The following is a description of a gene set: studied in species Homo sapiens Human Gene Set: GOBP_CONNECTIVE_TISSUE_DEVELOPMENT The progression of a connective tissue over time, from its formation to the mature structure., and this is the list of marker genes: UMODL1, SNX19, PRRX1, BBS1 (Bardet-Biedl syndrome 1), BBS2, HES5, ACAT1, RARB, MEX3C, BMP10, ZMPSTE24, SORL1, MIR125A, MMP13, SH3PXD2B, SMAD7, ID2, THRA, FKRP, MATN3, TGFB2, PTH1R, IL17F, PPARD, GPR82, FGF2, GREM1, BMP5, HAND1, PDGFA, PUM2, TRPM4, ECM1, MKKS, MYCN, TRPV4, LEP, CFLAR, ERRFI1, SCIN (scinderin), OSR2, RFLNA, PDGFB, LTBP3 (NCBI Gene Id 4054), NAMPT, TIMP1, MATN1, EGR1, ACTA2, PBXIP1, TBL1XR1, PARP1, CASR, FGFR3, ZBTB16, FOXC2, WNT2B, HYAL3, HSD17B1, PPARGC1A, GDF2, CER1, MGP, RARG, FGF4, COL3A1, SMAD5, PLAAT3, GLI3, PTHLH, RASAL2, BMPR2, AMELX, ZNF516, LUM (NCBI Gene Id 4060), DGAT2, EIF2AK3, NKX3-2, SPTLC2, NFIA, RUNX3, EPYC, TGFBR2, PKD1, ARRDC3, ARID5B, WNT5A, PAXIP1, SNAI1, GHRL, SLC39A13, ZNF219, IGF1, SLC39A14, AMER1, ADAMTS7, SMPD3 (NCBI Gene Id 79756), FOXA1, TRPS1, MAF, BMP7, TGFBI, PPARG, GDF5, ITGB3, ADAMTS12 (NCBI Gene Id 81792), MAPK3, CTNNB1, GUCA2B, COL6A1, CNMD, MIR21, LNPK, OSR1, KLF7, FGF6, TSKU, CSGALNACT1, PTH, SLC26A2, SATB2, PDGFRB, NCOA1, PDGFD, OTOR, SLC25A25, LIPA, MBOAT2, GHR, NOTCH1, CHI3L1, PGRMC2, WNT10B, OXCT1, RUNX1, CD44, EFEMP1, PIK3CA, BMP8B, EDN1, SMAD3, XBP1, CREB3L2, NPR2, BMP6, FRZB, VPS13B, WNT11, HYAL1, SPI1 (NCBI Gene Id 6688), HAND2, HYAL2, ADGRG6, NR5A2 (NCBI Gene Id 8768), CCN3, SELENOM, SCX, DYRK1B (dual specificity tyrosine phosphorylation regulated kinase 1B), GLG1, CD34, SERPINH1, SOX5, CD2AP, MSX2, BMPR1B, FGF9, EXT2, BMP4, BMP2, ASNSD1, IFT80, COL5A1, HOXA5, FGF18 (NCBI Gene Id 8817), HMGCS2, HOXB3, TGFB1, BBS4, EVC, CHSY1, TAPT1, COL1A1, THBS3, CCN4, PKDCC, WNT7B, CSF1, ENSG00000274276, FTO, GDF7, MSX1, AXIN2, SHOX2, GDF6, HOXA11, GPR4, SMAD1, FAM83A, WNT9A, COL27A1, MEF2C, ARID5A, HMGA2, HOXD3, BMP3, NFIB, OGN, PAX7, COMP, SIRT1, SOX8, MAPK14, SNAI2, TGFBR1 (transforming growth factor beta receptor 1), NFATC2, SERPINB7, NOG, WT1, BARX2, PRKG2, SOX6, GPLD1, POU4F2, CYTL1, IL6R, CHADL, RORC, TWSG1 (twisted gastrulation BMP signaling modulator 1), HOXC4, TRIP11, SPART, MIR138-1, RARA, LOXL2, OPTC, PTPN11, ID4, FOXD1, GALNT3 (NCBI Gene Id 2591), FGFR1, RFLNB, SIX2, LPL, POC1A (NCBI Gene Id 25886), MDK, UNCX, WNT7A (NCBI Gene Id 7476), PITX1, NPPC, SULF2, HOXA3, IHH, SOX9, ATP7A, BGN, MYF5, LOX, DDRGK1, IFRD2, UBB, ITGB8 (NCBI Gene Id 3696), CHRDL2, INHBE, ABHD15, CBS, ZEB1, COL2A1 (collagen type II alpha 1 chain), STC1, RUNX2, RSPO2, MUSTN1, SULF1, CTSK, HIF1A, RB1, BMPR1A, EXT1, HRAS, ATF2, BPNT2, LARGE1, ACVRL1, COL11A2, SNORC, CCN2, BMP1, CRIP1, LRP5, RXFP1, GATA3, POR, DLX2, IFRD1, COL11A1, CCN1, EBF2, SFRP2 (NCBI Gene Id 6423), KAT2A, NCOA2, CHST11, PRKAA1, WNT5B, FOSL2 (FOS like 2, AP-1 transcription factor subunit), BMP8A, SRF, NR1H4